The following is a description of a gene set: Abnormal pulmonary thoracic imaging finding species: Homo sapiens This term groups terms representing abnormal findings derived from chest X-ray investigation of the lung. In general, lung abnormalities can manifest as opacities (areas of increased density) or as regions with decreased density. Human Gene Set: HP_ABNORMAL_PULMONARY_THORACIC_IMAGING_FINDING, and this is the list of marker genes: DNAH11, CSF2RA, CCN2, SFTPA2, TP73, RIPK4, GAS8, PARN, CCR6, CFAP298, HBG1, RSPH3, SLC41A1, IFIH1, OFD1, NME5, CAPNS1, NHLRC2, STAT1 (signal transducer and activator of transcription 1), CXCR4, UBA1, TERT, ESAM, GP1BB, CFAP300, DNAI1, DNAAF4, TLR4, LPIN2, CYBB, FOXJ1, HBG2, RPGR, HIRA, DNAL1, DRC1, DNAI2, FAS, TTC12, SFTPA1, HLA-DRB1, B2M, STAT4, COL3A1, RTEL1, MUC5B, ZMYND10, RSPH9, BCL11A, NME8, BCL10, DNAJB13 (NCBI Gene Id 374407), BACH2, BIRC3, TSC2, APOE (apolipoprotein E), SPEF2, FAM13A, FASLG, UFD1, MEFV, DNAAF11, GAS2L2, HYDIN (HYDIN axonemal central pair apparatus protein), ODAD3, LTBP4, DSP, DNAAF1, SEC24C, C1QB, NCF2 (NCBI Gene Id 4688), SPAG1, LRRC56, CCDC39, TBX1, PRIM1, HLA-DPA1, PAX3, CFAP221, BMPR2, DNAH1, RAB27A, PTPN22, CCNO, MYD88, PLEC, ODAD1, RSPH1, NKX2-1, STAT3, IL12A, TSC1, KLRC4, IRF5, SMPD1, LAMA2, TERC, SLC34A2, ODAD2, MCIDAS, DNAAF6, ABCA3, CFAP74, OCRL, CCR1, KLF1, STK36, BCL6 (NCBI Gene Id 604), DOCK2, SFTPC, BCL2, IL12A-AS1, CASP10, STN1, COMT, IL10, DNAAF5, DNAAF2, DNAH5, SFTPB, MALT1, NEK10, DPP9, HLA-DPB1, HLA-B, ARVCF, ATP11A, C4A, CAV1, CSF2RB, FOXP1, BTNL2, EIF2AK4, ASAH1, HBB, IL2RA, KIF1B, IFNGR1, JMJD1C, DNAAF3, GBA1, CTLA4, DNAH9, ODAD4, UBAC2, B3GALT6, CCDC40, PRTN3, ERAP1, AGR2, PDCD1, PDGFRA, RSPH4A, IL23R, RREB1